The following is a description of a gene set: species: Mus musculus A nuclear receptor activity regulated by steroid binding and modulating the transcription of specific gene sets transcribed by RNA polymerase II. Mouse Gene Set: GOMF_NUCLEAR_STEROID_RECEPTOR_ACTIVITY, and this is the list of marker genes: Pgr, Pde3a, Rxrb, Or51e2, Gper1, Ppara, Nr3c1, Esrra, Rxra, Paqr8, Rxrg, Esr1, Esr2, Esrrb, Abhd2, Paqr7, Esrrg, Nr3c2